Given this list of marker genes SIRT6, ARHGEF5, FHL2, KLF3, ABHD2, SH2D4A, CTU2, FOLR2, SERPINF1, LENG9, BIRC5, MKRN1, CDR2, CD163, PCK2, MAD2L1BP, EPS8, GTF3C4, B4GALT6, SLC16A11 (solute carrier family 16 member 11), TEX12, KCNIP4, FGFR1, RBM15, SCN3B, NELFB, TBC1D10B, GPR143, SERINC2, TSPAN5, RAD51B (RAD51 paralog B), PTK2, ITPKA, SLC35C1, GLUL, CLIC1, GPN1, EMP3, HTR2A, SMAGP, HEXD, PSD3, SERINC3, INSR, TST, TSPAN17, ACTL7B, SP6, BRI3, CRKL, ADAM33, ADD3, PCDH7, STXBP6 (NCBI Gene Id 29091), SLC12A2, SLC28A2, TENT4A, CHST7, OXCT1, CAST (calpastatin), YPEL1, SLC35E3, CFH, TNFAIP8L1 (TNF alpha induced protein 8 like 1), ADGRE1, CDX2, PEG10, IGFLR1 (IGF like family receptor 1), CCL24, UBTFL1, CCL28, CDK14, S100A4, FBP2, GNA11, EGFR, SPTLC2 (serine palmitoyltransferase long chain base subunit 2), SLC14A1, MOSPD1, LANCL1, RRAS, SETD7, PALB2, WWP1, CDKN2C, ERBB3, MRC1, NRF1, TMEM141, KCTD20, RNF141, AHNAK, CCL2, NIPAL2, CDC42BPA, IQGAP2, RHOBTB1, ATXN7L1, APP, ACVR2A, TMEM117, GRN, F13A1, PABPC4 (poly(A) binding protein cytoplasmic 4), CLPX, SYPL1, IL5, STOM, ATP6V0A1, SLC7A13, DKC1, PLAC8, BLOC1S5, JPT1, CERS2, EIF4EBP2 (NCBI Gene Id 1979), PARP14, PRRC1, TSPAN12, FADS2, ARHGAP35, NECTIN3, CMAHP, MEF2C, PID1, LAMC1, NME4, TRIM2, YPEL5, ADA, PPP4R1, CTTNBP2NL, CTSD, LYVE1, DTNB, CMTM3, TMEM45B, LGALS1, TPK1, WDCP, PM20D1, EHD4, CD36, RASGRP3, SPATS2L, ZFPL1, here is a description of the gene set: from publication Dudziak D, Kamphorst AO, Heidkamp GF, Buchholz VR, Trumpfheller C, Yamazaki S, Cheong C, Liu K, Lee HW, Park CG, Steinman RM, Nussenzweig MC (PMID 17204652) Genes up-regulated in cells from Flt3L Melanom injected mice: 33D1+ versus CD4 T cells. Dendritic cells (DCs) process and present self and foreign antigens to induce tolerance or immunity. In vitro models suggest that induction of immunity is controlled by regulating the presentation of antigen, but little is known about how DCs control antigen presentation in vivo. To examine antigen processing and presentation in vivo we specifically targeted antigens to the two major subsets of DCs using chimeric monoclonal antibodies. Unlike CD8+ DCs that express the cell surface protein CD205, CD8- DCs, which are positive for the 33D1 antigen, are specialized for presentation on MHC class II. This difference in antigen processing is intrinsic to the DC subsets and associated with increased expression of proteins associated with MHC processing. Human Gene Set: GSE6259_FLT3L_INDUCED_33D1_POS_DC_VS_CD8_TCELL_UP studied in species Homo sapiens